Given this list of marker genes IGSF11, HIVEP2, TTC9B, SELENOO, IDH3B, FUT2, FOLR1 (NCBI Gene Id 2348), ZNF157, AARS2, UCKL1, GIP, TMEM186, SERF2, TNFRSF13B, TMEM14C, HOXA7, ELF4, RNF17, KCNT2, MORN4, GPR152 (NCBI Gene Id 390212), STX4, MFSD9, PTCD1, LRP2BP, TCEA2, SMDT1, HTR5A, MYORG, SEC14L5, SMPD5, EBF4, ZNF623, TCAF2, YIPF2, ZNF646, HOXB2, RORA, STUB1 (STIP1 homology and U-box containing protein 1), MCAM, PDRG1, CPA1, TMEM151B, DENND2C, CTSW, EHD2, PIK3IP1, ST6GALNAC5 (NCBI Gene Id 81849), PROSER2, NKX2-5, ACKR3, KRTAP15-1, GPR19, VPS26B, TMEM175, CNIH1, PPP1R3C, NRARP, MRPS26, SLC22A8, RASAL2, ERG, RNF32, ZFP14, MYH6, LEFTY1, NEXMIF, NDUFB10, CHPF, DDHD1, QNG1, VTI1B, SNX1, CIZ1, PRSS23, RBX1, SRFBP1, UCP3, DUSP7, STX17, AJM1, RGS9BP, BRD2, PNPLA1, NFAM1, NPEPL1, GJB6, INHBC, GPR182, PRR27, TMEM120B, NT5C, CCDC85A, SCN9A, IL9R, RIOX1, CCN3, GPR22, H2AC25, GRM7, C16orf54, ECEL1, TOP3B, KLHDC8A, LDAF1, ACOT11, TRPM3, CRP, CEP78, HMGB1, CAPSL, ABHD17A, MYMK, TMEM134, IPPK, CHCHD7, CHP2, AGBL3, ATG12, NDUFS8, OSGIN1, GIPC2, S100G, TLR4, TMEM50A (transmembrane protein 50A), RP1, KRT25, PAPOLB, RTN1, GPR143, ITGB6, SLX4, GBGT1, DNAJC28, GIPC1, PARD6A, RPS5, CPM (NCBI Gene Id 1368), IMP4, LPAR6, TMEM208, KLF15, ANGPTL7, USF1, SEL1L3, SLC27A1, SNHG10, PHYHD1, GRIP1, HSD17B14, CNDP2, LIPK, EARS2, TCTE1, E2F4, ZBED5, CCDC18, TRARG1, SPRYD4, CISD1, ADAMTS4, H3C4, ZMPSTE24, MIR124-1HG (MIR124-1 host gene), LTO1, MST1, MEPE, IGFBP1, CBX7, TRPV4, PSME1, PDP2, B3GNTL1, ATP1A2, NIPAL2, ZCCHC13, CIAO3, FBXO16 (NCBI Gene Id 157574), SLC7A3, TSPAN1, P3H1, ADAM2, PI4KB, PTGER3, EPHX2, NEFM, GBA1, NUDT18, CCDC54, MACROH2A1, ERG28, ROPN1, FTCD, SDF4 (NCBI Gene Id 82832), CTTNBP2, SDHB, NRP2, MRPL46, here is a description of the gene set: Human Gene Set: GSE46606_UNSTIM_VS_CD40L_IL2_IL5_1DAY_STIMULATED_IRF4HIGH_SORTED_BCELL_UP studied in species Homo sapiens from publication Ochiai K, Maienschein-Cline M, Simonetti G, Chen J, Rosenthal R, Brink R, Chong AS, Klein U, Dinner AR, Singh H, Sciammas R (PMID 23684984) Temporal analysis of B cell activation in vitro using CD40L and IL-2/4/5 cytokines in wild type Irf4+/+ B cells or in mutant Irf4-/- B cells harboring a tet-inducible allele of Irf4. IRF4 expression was restored, or not, in the Irf4-/- background by culturing in the presence of low or high concentrations of doxycycline. The results provide insight in the role of IRF4 expression levels in coordinating different programs of B cell differentiation. Genes up-regulated in at day 0 B cell IRF4-KO versus CD40L and IL-2 IL-4 IL-5 stimulated at day 1 B cell IRF4high.